The following is a description of a gene set: from publication Rubenstein AB, Smith GR, Raue U, Begue G, Minchev K, Ruf-Zamojski F, Nair VD, Wang X, Zhou L, Zaslavsky E, Trappe TA, Trappe S, Sealfon SC (PMID 31937892) species: Homo sapiens Human Gene Set: RUBENSTEIN_SKELETAL_MUSCLE_B_CELLS, and this is the list of marker genes: GTF3A, RPL3, ITSN2, TBC1D10C, OAZ1, PAPOLA, CTSS, NPM1, UBA52, RPSA2, CALHM6, CD79B, RPL23, PLPP5, RPL7, EIF4A2, RPLP2, C1orf56, NOP53, RPL4, MT-CO1, CMTM6, MS4A1, RPS24, RPS27, DRAM2 (NCBI Gene Id 128338), RHOH, HLA-DMA (NCBI Gene Id 3108), RPL19, ERP29, CCDC32, RPL36A, PAIP2, CD37, GAPT, RPL13A, RPS6, COX7C (cytochrome c oxidase subunit 7C), CD48, VPREB3, NCF1, EAF2, FAU, RPS15, ALOX5AP, RPS18, FCER2, BANK1, EEF1B2, RPS5, RPL37, RPS4Y1, HLA-DPB1, CD79A, RPS29, WDR74, HLA-DOB, TRIM22, CASP4, PLAC8, CYBA, RPS10, SMDT1, RPL18A, IRF8, TSC22D3, PFDN5, POLD4, PTPRCAP, RACK1, RPL21, RPS25, RPL7A, HLA-DQB1, RPS3, PTPRC, CD69, RPL41, RPS7 (NCBI Gene Id 6201), RPL22, EEF1D, RPL32, BTG1, RPL11, CD83, RPL5, GMFG, RPL9, RPL26, NOP10, RPLP1, HVCN1, RPL8, SNX2, CYRIB, RPL29, RPL38, RPL23A, TPD52, ATP6V1G1, RPS27A, RPS12, SELL, PYM1, ARHGAP24, RPL18, ACTR3, RPL14, PLEKHF2, STK4, RPS21, FCRL1, CARD16, SSR1 (NCBI Gene Id 6745), RPL15, CD52, LIMD2, LAPTM5 (lysosomal protein transmembrane 5), ARPC3, RPS26, HLA-DRB1, C1orf162, RSRP1, RPL39, RPS9, TCL1A, TMEM243, RPS23, RASGRP2, RPS19, JUNB, RPL27A, RPS13, RPS28, RPL34, RPS8, PABPC1, RPL28, OSTF1 (NCBI Gene Id 26578), RPL30, RPL27, RPS4X, SNHG8, LTB, B4GALT1, RPL37A, RPL10, JCHAIN, RPL35A, RPL12, RNASET2, HLA-DRA, CD53, LINC00926, RPL36, HLA-DQA1, FCRLA, PPP1R2, RPL6, CLK1 (NCBI Gene Id 1195), HLA-DPA1, RPS15A, RPSA, EEF1A1, FCMR (NCBI Gene Id 9214), RAC2, RPL13, BTK, BTLA, RPS14, LY86, RPS3A, RPS2, CXCR4 (NCBI Gene Id 93405), GPR183, EVI2B, CD74